Given this list of marker genes CYP1A2, CYP2E1, CYP2D6, CYP2C8, CYP3A4, CYP2C9, here is a description of the gene set: Biosynthesis of maresin-like SPMs species: Homo sapiens Human Gene Set: REACTOME_BIOSYNTHESIS_OF_MARESIN_LIKE_SPMS